Given this list of marker genes XCL1, IL6, LCP2, IL13, CCL2, STAT4, IL9, IFNB1, IL12B, CCL23, IL23R, IL17D, VPREB3, IRF7, IFRD1, CXCL9, CXCL10, BOK, BLNK, PIAS2, IRGM, IL4I1, IFNAR1, CX3CL1, IL2RG, NFKB1, IL7R, PIAS3, CCL4, CCR7, IL4, LY6D, here is a description of the gene set: from publication Worschech A, Kmieciak M, Knutson KL, Bear HD, Szalay AA, Wang E, Marincola FM, Manjili MH (PMID 18381452) studied in species Mus musculus Selected genes with immunologic function which were reciprocally changed in evasion and tolerogenic tumor models. Human Gene Set: WORSCHECH_TUMOR_EVASION_AND_TOLEROGENICITY_UP We have previously shown T-cell-mediated rejection of the neu-overexpressing mammary carcinoma cells (MMC) in wild-type FVB mice. However, following rejection of primary tumors, a fraction of animals experienced a recurrence of a neu antigen-negative variant (ANV) of MMC (tumor evasion model) after a long latency period. In the present study, we determined that T cells derived from wild-type FVB mice can specifically recognize MMC by secreting IFN-gamma and can induce apoptosis of MMC in vitro. Neu transgenic (FVBN202) mice develop spontaneous tumors and cannot reject it (tumor tolerance model). To dissect the mechanisms associated with rejection or tolerance of MMC tumors, we compared transcriptional patterns within the tumor microenvironment of MMC undergoing rejection with those that resisted it either because of tumor evasion/antigen loss recurrence (ANV tumors) or because of intrinsic tolerance mechanisms displayed by the transgenic mice. Gene profiling confirmed that immune rejection is primarily mediated through activation of IFN-stimulated genes and T-cell effector mechanisms. The tumor evasion model showed combined activation of Th1 and Th2 with a deviation toward Th2 and humoral immune responses that failed to achieve rejection likely because of lack of target antigen. Interestingly, the tumor tolerance model instead displayed immune suppression pathways through activation of regulatory mechanisms that included in particular the overexpression of interleukin-10 (IL-10), IL-10 receptor, and suppressor of cytokine signaling (SOCS)-1 and SOCS-3. These data provide a road map for the identification of novel biomarkers of immune responsiveness in clinical trials.